Given this list of marker genes STAT5A, CAV1, NCOR2, ATP7B, CCND1, VEGFA, CDO1, MTX1, NME1, STAT5B, ZBTB7B, GHRHR, XBP1, UPRT, GPAT4, USF2, OAS2 (NCBI Gene Id 4939), DDR1, SOCS2, SLC29A1, FOXB1, PRLR (NCBI Gene Id 5618), CREB1, ABCB1, CSN2, XDH, NCOA1, CAD, NEURL1, VDR, SLC6A3, ERBB4, MT-CO2, PRL, MTCO2P12, CSN3, MED1, HK2, APLN (NCBI Gene Id 8862), OXTR, HIF1A, here is a description of the gene set: species: Homo sapiens Human Gene Set: GOBP_LACTATION The regulated release of milk from the mammary glands and the period of time that a mother lactates to feed her young.